The following is a description of a gene set: Neuroblastoma in advanced stages is one of the most intractable paediatric cancers, even with recent therapeutic advances. Neuroblastoma harbours a variety of genetic changes, including a high frequency of MYCN amplification, loss of heterozygosity at 1p36 and 11q, and gain of genetic material from 17q, all of which have been implicated in the pathogenesis of neuroblastoma. However, the scarcity of reliable molecular targets has hampered the development of effective therapeutic agents targeting neuroblastoma. Here we show that the anaplastic lymphoma kinase (ALK), originally identified as a fusion kinase in a subtype of non-Hodgkin's lymphoma (NPM-ALK) and more recently in adenocarcinoma of lung (EML4-ALK), is also a frequent target of genetic alteration in advanced neuroblastoma. According to our genome-wide scans of genetic lesions in 215 primary neuroblastoma samples using high-density single-nucleotide polymorphism genotyping microarrays, the ALK locus, centromeric to the MYCN locus, was identified as a recurrent target of copy number gain and gene amplification. Furthermore, DNA sequencing of ALK revealed eight novel missense mutations in 13 out of 215 (6.1%) fresh tumours and 8 out of 24 (33%) neuroblastoma-derived cell lines. All but one mutation in the primary samples (12 out of 13) were found in stages 3-4 of the disease and were harboured in the kinase domain. The mutated kinases were autophosphorylated and displayed increased kinase activity compared with the wild-type kinase. They were able to transform NIH3T3 fibroblasts as shown by their colony formation ability in soft agar and their capacity to form tumours in nude mice. Furthermore, we demonstrate that downregulation of ALK through RNA interference suppresses proliferation of neuroblastoma cells harbouring mutated ALK. We anticipate that our findings will provide new insights into the pathogenesis of advanced neuroblastoma and that ALK-specific kinase inhibitors might improve its clinical outcome. Human Gene Set: CHEN_NEUROBLASTOMA_COPY_NUMBER_GAINS studied in species Homo sapiens High-grade amplification (copy number, CN >= 5) detected in primary neuroblastoma samples. from publication Chen Y, Takita J, Choi YL, Kato M, Ohira M, Sanada M, Wang L, Soda M, Kikuchi A, Igarashi T, Nakagawara A, Hayashi Y, Mano H, Ogawa S (PMID 18923524), and this is the list of marker genes: NAV2, RNASEH1, GABPB2, HDC, DUT, FGF7, LYVE1, STIM1, IRAG1, BRD9, ODC1, EIPR1, SLC27A2, TRIP13, HDAC3, FBN1, TNRC6A, RNF141, RPS7, ARAP3, NKD2, DFFB, TRIM23, RNF144A, HPCAL1 (NCBI Gene Id 96763), YPEL5, MYEOV, TRAPPC12, ACP1, GALK2, ALK, PDIA6, PPWD1, SH3YL1, ZFHX3, TPO, HSD17B2, TH, WWOX, CDH13, IGF2, TAF7, INS, TERT, RBBP6 (NCBI Gene Id 84712), SGTB, MYCN, CACNG3, MYT1L, TAF1B